Given this list of marker genes Chn1, Src, Epha7, Efna2, App, Pik3cg (NCBI Gene Id 76039), Grb2, Fyn, Efnb1, Sdcbp, Cdk5r1, Nck1, Efna4, Lyn, Epha4 (Eph receptor A4), Tiam1, Anks1b, Efnb2, Cdk5, Crk, Ptpn1, Abl1, Efna1, Shc1, Efnb3, Ngef (neuronal guanine nucleotide exchange factor), Efna3, Anks1, Efna5, Aqp1, Cbl, Sipa1l1, here is a description of the gene set: Mouse Gene Set: GOMF_EPHRIN_RECEPTOR_BINDING studied in species Mus musculus Binding to an ephrin receptor.